Given this list of marker genes Aff4, Tcea1, Polr2f, Polr2b, Gtf2h3, Ercc2, Polr2a, Supt5, Ctr9, Ccnt2, Iws1, Eaf1, Mnat1, Cdk7, Polr2d, Ctdp1, Ccnt1, Polr2i, Eaf2, Polr2c, Mllt3, Leo1, Polr2h, Supt4a, Polr2l, Nelfe, Skic8, Gtf2h4, Eloc, Cdk9, Ssrp1, Gtf2f2, Gtf2f1, Elob, Paf1, Ncbp1, Cdc73, Gtf2h2, Eloa, Nelfcd, Supt6, Polr2g, Ercc3, Gtf2h5, Polr2k, Gtf2h1, Ell, Ccnk, Ccnh, Polr2e, Ncbp2, Nelfa, Nelfb, Mllt1, Supt16, here is a description of the gene set: Mouse Gene Set: REACTOME_FORMATION_OF_RNA_POL_II_ELONGATION_COMPLEX Formation of RNA Pol II elongation complex species: Mus musculus